The following is a description of a gene set: Human Gene Set: GOBP_THYROID_HORMONE_GENERATION species: Homo sapiens The formation of either of the compounds secreted by the thyroid gland, mainly thyroxine and triiodothyronine. This is achieved by the iodination and joining of tyrosine molecules to form the precursor thyroglobin, proteolysis of this precursor gives rise to the thyroid hormones., and this is the list of marker genes: GATA3, HPN, SLC16A2, CPQ (carboxypeptidase Q), MED1, SLC5A5, DUOXA1, DIO1, FOXE1, CTSB (NCBI Gene Id 3896), TPO, DUOXA2, SLC26A7, DUOX1, TG, SLC16A10, CTSK, DIO2, CGA, DUOX2, PAX8, SLCO1C1